The following is a description of a gene set: This event has been computationally inferred from an event that has been demonstrated in another species.<p>The inference is based on the homology mapping from PANTHER. Briefly, reactions for which all involved PhysicalEntities (in input, output and catalyst) have a mapped orthologue/paralogue (for complexes at least 75% of components must have a mapping) are inferred to the other species. Reactome Pathway: RAC2 GTPase cycle studied in species Mus musculus part of: RHO GTPase cycle electronically inferred by orthology from the curated human pathway, and this is the list of marker genes: Ncf2, Mcam, Racgap1, Arhgap42, Slitrk5, Depdc1b, Mpp7, Lbr, Vav1, Rac2, Ankle2, Cdc42, Vrk2, Lamtor1, Baiap2l1, Swap70, Arhgap26, Pik3r2, Prex1, Samm50 (NCBI Gene Id 68653), Dock2, Emd, Ophn1, Epha2, Cyba, Esyt1, Ncf1, Cav1, Arhgap17, Armcx3, Pld2, Lman1, Vangl1, Pgrmc2, Pak4, Rab7